Given this list of marker genes CELF2, HFM1, NAV2, ELL3, PICALM, DDX3X, UBE2E3, SPOPL, METAP2, FOXN3, PRKACB, FNDC3B, AQP4, ERBIN, SLC35F1, LAMC1, SYNGAP1, IL17RC, PTGER2, SLC39A14 (solute carrier family 39 member 14), GFRA2, DCTN5, CHRD, GNAI2, PTN, HAPSTR1, PCDH19, SRGAP3 (NCBI Gene Id 9901), GTF2B, LYPD6, CD200, NCAM1, HDGF, FBXO11 (NCBI Gene Id 80204), REM2, RIMS2, GPR83, MOSPD1, RIMS4, WDR48, ZNF664, HAO1, KMT5A, SIX4, UBR3, ATP2C1, SRSF7, POM121, UNC5C, YY1, NLK, GPM6B, PRDM4, ARFIP2, EPC2, SYTL2, BABAM2, USO1, ASAP2, EXOC5, ACVR1, THBD, SMG1, ESRRG, here is a description of the gene set: Human Gene Set: CTAGGAA_MIR384 species: Homo sapiens Genes having at least one occurence of the motif CTAGGAA in their 3' untranslated region. The motif represents putative target (that is, seed match) of human mature miRNA hsa-miR-384 (v7.1 miRBase).